Given this list of marker genes DOCK5, ADRA2B, MAP2K1, P2RX1, ARHGAP42, DOCK4, STUB1, ZDHHC21, MIR21, ATP2B1, RHOA, here is a description of the gene set: Human Gene Set: GOBP_REGULATION_OF_VASCULAR_ASSOCIATED_SMOOTH_MUSCLE_CONTRACTION Any process that increases the frequency, rate or extent of vascular smooth muscle contraction. studied in species Homo sapiens